The following is a description of a gene set: Genes involved in protein secretion pathway. from publication Liberzon A, Birger C, Thorvaldsdóttir H, Ghandi M, Mesirov JP, Tamayo P (PMID 26771021) Human Gene Set: HALLMARK_PROTEIN_SECRETION studied in species Homo sapiens, and this is the list of marker genes: RAB22A, GNAS (NCBI Gene Id 82944), IGF2R, ARFGEF1, CLTC, TMX1, YIPF6, PAM, COPB1, VPS45, RPS6KA3, ADAM10, ATP7A, USO1, ARCN1, SGMS1, RAB9A, RAB5A, COPB2, TPD52, SSPN, TSG101, STX7, NAPG, DOP1A, STAM, SNAP23, MON2, VAMP3, EGFR, SEC31A, ABCA1, AP2B1, CLCN3, ERGIC3, YKT6, SEC22B, VAMP4, PPT1, ANP32E, M6PR, RER1, CD63, STX12, TSPAN8, DST, GOSR2, VAMP7, GOLGA4, ATP1A1, MAPK1, CTSC, BNIP3, TMED2, SCRN1, ARFGAP3, TMED10, GBF1, AP1G1, ATP6V1H, KIF1B, NAPA, ZW10, ATP6V1B1, KRT18, RAB2A, VPS4B, RAB14, LMAN1, SEC24D, LAMP2, SNX2, SH3GL2, TOM1L1, ICA1, COG2, BET1, SOD1, ARF1 (NCBI Gene Id 375), ARFIP1, SCAMP1, AP2M1, STX16, COPE, GLA, AP3B1, CLN5, GALC, AP2S1, CLTA, OCRL, ARFGEF2, SCAMP3, AP3S1, DNM1L, CAV2